The following is a description of a gene set: The gene expression profile of peripheral Foxp3+ natural regulatory T cells isolated from Foxp3/EGFP bicistronic mice was compared to that of in vitro-induced regulatory T cells and to CD4+ conventional (Foxp3-) T cells. The role of the regulatory T cell transcription factor Foxp3 in shaping the transcriptosomes of natural and induced regulatory T cells was analyzed using mice expressing a mutant FOXP3-EGFP fusion protein (Foxp3deltaEGFP). We used gene expression microarrays to examine the transcriptional programs of natural and induced regulatory T cells and the function of Foxp3 in organizing the transcriptosomes of the respective cell type Genes down-regulated in T reg: induced versus natural. Human Gene Set: GSE14415_INDUCED_VS_NATURAL_TREG_DN from publication Haribhai D, Lin W, Edwards B, Ziegelbauer J, Salzman NH, Carlson MR, Li SH, Simpson PM, Chatila TA, Williams CB (PMID 19265124) studied in species Homo sapiens, and this is the list of marker genes: IFITM1, ZNF106, SSR1, MMP8, RBM3 (RNA binding motif protein 3), SNX5 (sorting nexin 5), CDC25C, SAE1, WDHD1, DEPDC1B, PRDX3, EXO1, DCTPP1, COX5B, NCAPG2, SMC3, MKI67, HK2, NME1, TDRD6, UBR7, CKAP5, ASPM, RAD51, GINS1, CORO1A, HSPD1, DLGAP5, P2RY13, NUDT1, LANCL2, ANAPC5, CCNB2, KIF15, HADH, MCM3, IGF2BP3, TPX2, HMGN2, KIF4A, ITGAX, BIRC5, CANX, BUB1, CHMP2A, CDCA7, MRPL18, H2AC4, FPR1, SHCBP1, ARHGAP19, LGALS3, GPR146, MCM2, MPO, TEX9, RPL41, CCNA2, CENPH, ATAD5, NUF2, SGO1, FKBP8, AARSD1, GEN1, RPN1, VCAN, MCM5, GPR55, CDK1, ARL6IP4, NAP1L1, CDCA8, GDA, PLK4, NOL12, PDCL3, TRIP13, CDCA3, TAF1D, ADAP1, CCR9, H2BC14, KIF11, CENPA, STMN1, MIS18BP1, RBM17, ISOC1, LMAN1, WARS1, PSMC3IP, FKBP2, NCAPG, KPNA2, NR1I3 (nuclear receptor subfamily 1 group I member 3), PBK, TTK, ALDOA, SDAD1, ACAA2, API5, RAD54L, SEH1L, ITGA1, CEP55, ECT2, INCENP, PDIA3, BUB1B, CLSPN, KIF23, HASPIN, NEIL3, CALM1, PTPN6, MS4A3, PLA2G7, RRM1, KLRG1, CKAP2L, IL1RL2, PTGR1, TPM4, KNL1, CDC45, TTC9C, HDAC3, MT2A, SAP30BP, SPC24, KIF2C, LMNB1, TIPIN, KIF22, PIGT, CLEC12A, BRCA1, ITGB3, H2BP2, HMMR, BST2, TOP2A, GSTT2, CD274, EZH2, GLIPR2 (GLI pathogenesis related 2), POLA1, PSMD8, SKAP2, ALG8, CENPF, SMC2, CENPN, TACC3 (transforming acidic coiled-coil containing protein 3), CENPS, DESI2, KIF14, CAPG, CCS, IL1RL1, NRM (nurim), PCBP1, TUBGCP2, H1-5, PLAC8, PALS2, ASF1B, TPI1, PLK1, EPSTI1, PMF1, MELK, ARHGAP11A (Rho GTPase activating protein 11A), NUDCD1, MRPL21, ITIH5 (NCBI Gene Id 84903), ERAP1, E2F8, MYB, CKS1B